Given this list of marker genes Dcp2, Nudt16l1, Nudt5 (NCBI Gene Id 53893), Dcp1a, Nudt1, Nudt3, Nudt7, Nudt4, Nudt16, Dcp1b, here is a description of the gene set: Catalysis of the reaction: a 5'-end (N7-methyl 5'-triphosphoguanosine)-ribonucleoside in mRNA + H2O = a 5'-end phospho-ribonucleoside in mRNA + N7-methyl-GDP + H+. Mouse Gene Set: GOMF_5_N_7_METHYLGUANOSINE_5_TRIPHOSPHO_MRNA_HYDROLASE_ACTIVITY studied in species Mus musculus